Given this list of marker genes Grn, Nr1d1, Cx3cl1, Tafa3, Pparg, Cst7, Ldlr, Syt11, here is a description of the gene set: studied in species Mus musculus Any process that stops, prevents or reduces the frequency, rate or extent of microglial cell activation. Mouse Gene Set: GOBP_NEGATIVE_REGULATION_OF_MICROGLIAL_CELL_ACTIVATION